The following is a description of a gene set: studied in species Homo sapiens Genes up-regulated in CD4 T conv over-expressing: FOXP3 versus XBP1 and FOXP3. from publication Fu W, Ergun A, Lu T, Hill JA, Haxhinasto S, Fassett MS, Gazit R, Adoro S, Glimcher L, Chan S, Kastner P, Rossi D, Collins JJ, Mathis D, Benoist C (PMID 22961053) The transcription factor FoxP3 partakes dominantly in the specification and function of FoxP3+ CD4+ T regulatory cells (Tregs), but is neither strictly necessary nor sufficient to determine the characteristic Treg transcriptional signature. Computational network inference and experimental testing assessed the contribution of several other transcription factors (TFs). Enforced expression of Helios or Xbp1 elicited specific signatures, but Eos, Irf4, Satb1, Lef1 and Gata1 elicited exactly the same outcome, synergizing with FoxP3 to activate most of the Treg signature, including key TFs, and enhancing FoxP3 occupancy at its genomic targets. Conversely, the Treg signature was robust to inactivation of any single cofactor. A redundant genetic switch thus locks-in the Treg phenotype, a model which accounts for several aspects of Treg physiology, differentiation and stability. Human Gene Set: GSE40274_FOXP3_VS_FOXP3_AND_XBP1_TRANSDUCED_ACTIVATED_CD4_TCELL_UP, and this is the list of marker genes: C8A, TMEM150A, CDC42BPA, LDLRAD1, QPCT, CYSLTR2, BAIAP2L2, MTTP, C11orf87, CRNN, COX7A1, SGO2, ATP2C2, H2BC1, UBXN2B, LLGL2, SMCP, S1PR5, CDKN2A, NEBL, ZFAND4, MYOZ1, PRELID2, SPIN3, CDC25C, ADAMTS1, RETSAT, LMX1A, RNF151, TRIP6, MYADML2 (myeloid associated differentiation marker like 2), ITGA11, LRFN3, RSPO2, ARL11, CDCA2, UCN2, HIP1, ATP2A1, WBP1, CX3CR1, WDR5B, CGA (glycoprotein hormones, alpha polypeptide), SOAT2, SLC16A2, PSMG3, DECR1, HTRA3 (NCBI Gene Id 94031), ADAM2, FZD1, ELL, TEKTL1, CDCA5, FOSL2, CMTM3, NELFE, NEFL, NDC80, SHISA9, COL4A4, FLT1, IGFBP5, FAM81B, PLCG2, MCUB, ANKRD6, MFSD6L, STX7, ID2, IL1F10, SLC66A2, H4C16, SLC10A4, KRT7, LGI3, SYCE1, MORN1, CIT, MYMK, ARID3C (AT-rich interaction domain 3C), ZYG11A, ITGA1, KLRC1, EFNA4, SRRM4, CLSTN3, TGM4, GCDH, ADAM8, PDE8B, LAMA2, C2CD4C, USP49, ANO7, PLCD1, ZFYVE19, MTFR2, CALHM2, TNFAIP6 (NCBI Gene Id 7130), FGL1, CHIA, INPP5J, NUDT2, PF4, CCDC150, COL9A1, RFX6, FANCL, CENPS, CCDC40, NPL, CLEC4E, FGL2, SLC45A4, COL5A1, KCNC4 (NCBI Gene Id 3749), NMRAL1, CNBD1, PLIN4, POLA1, RBP4, TNS1, H2BC9, KNDC1, BCL2L10, LRIG3, TPPP3, ESPL1, TSGA10IP, PRKAR2B, SLC16A3, ENTPD1, BCL6, TRAPPC3L, SCNN1B, ZNRF3, ADGRG5, CUL7, DYNLT3, MIP, RIPOR3, HTR5A, PHACTR2, PIGG, SPZ1 (NCBI Gene Id 84654), RNF144A, DNAJB13, MOV10L1, SYNGR3, TAAR9